Given this list of marker genes ZFAND5, SLC35E2A, PLPPR4, PHC1, NSD2, PRRC2B, NGRN, USP22, APPL2, EXOSC6, PGRMC2, ASTN2, ZFTA, BRPF3, RALGAPB, AMER2, CDIPT, DCAF7, GTF3C4, AFDN (afadin, adherens junction formation factor), PHF2, DCX, TSPYL4, PKNOX1 (NCBI Gene Id 5316), HGS, MTMR3, ERBB4 (NCBI Gene Id 2066), RBM8A, TMEM237, DCTN4, NFIB, DLG5, TNPO2 (transportin 2), ZNF84, NCAM1, ZBTB5, GSTA4, PPIG, BMPR2, PHF10, WSB2, BRD2, CSRNP2, WBP2, UBE2E3, NISCH, KLHL11, VPS26B, KIDINS220, MSI1, C2CD5, ATAT1, IPO9, RALGPS1, POGZ, RBM4B, CLEC16A, RERE, IQCK, RBFOX2, CALM1, APBB3, MED13, ARB2A, FOXO3, SLC8A2, ABHD14A, MAP6, here is a description of the gene set: Neighborhood of GSTA4 glutathione S-transferase A4 in the GCM expression compendium species: Homo sapiens Neighborhood of GSTA4 Human Gene Set: GCM_GSTA4